The following is a description of a gene set: studied in species Mus musculus Mouse Gene Set: REACTOME_GLYCINE_DEGRADATION Glycine degradation, and this is the list of marker genes: Gldc, Dld, Gcsh, Mrps36, Ogdh, Amt, Dlst